Given this list of marker genes Stag1, Hdac8, Chtf8, Cdca5, Gtf2b, Hormad2, Atrx, Smc1b, Sgo1, Meikin, Esco2, Ppp2r5c, Haspin, Ppp2r1b, Dscc1 (NCBI Gene Id 72107), Bub1b, Smc5, Hormad1, Cdc20, Esco1, Rec8, Slf2, Pds5a, Naa50, Phb2, Smc3, Slf1, Ppp2r1a, Mau2, Sgo2a, Pttg1, Bub1, Rb1, Axin2, Rad21l, Ctnnb1, Nsmce2, Tnks (tankyrase, TRF1-interacting ankyrin-related ADP-ribose polymerase), Kif22, Smc1a, Pogz, Ppp2r5d, Stag2, Wapl, Naa10, Cdk11b, Rad21, Rad51c, Nipbl, Mcmbp, Sycp3, Mre11a, Macroh2a1, Stag3 (NCBI Gene Id 50878), Sgo2b, Fen1, Ddx11, Fbxw7 (NCBI Gene Id 68467), Recql4 (RecQ protein-like 4), Sfpq (NCBI Gene Id 78315), Pds5b, here is a description of the gene set: Mouse Gene Set: GOBP_SISTER_CHROMATID_COHESION species: Mus musculus The cell cycle process in which the sister chromatids of a replicated chromosome become tethered to each other.